Given this list of marker genes Serf2, Hdac8, Supt4a, Mrtfb, Plaat3, Tafa2, Tsg101, Prkce, Pawr, Nck1, Ncoa3, Cxcl16, Nr2f2, Rpl17, Magi1, Lsamp, Chd6, Terf2ip, Plxdc2, Gem, Nectin3, Trmt112, Il18r1, Insig1, Tmem207 (transmembrane protein 207), Atf6, Usp37, Adamtsl3, Snrpn, Cnppd1, Lrrc56, Prrg4, Eif4enif1, Lclat1, Myo16, Parp8, Ankfy1, Zfp790, Dtna, Klhl31, Ube2d3, Tubgcp4, Elovl2, Timp2 (tissue inhibitor of metalloproteinase 2), Brwd3, Kif5c, Tmem252, Cyp26b1 (cytochrome P450, family 26, subfamily b, polypeptide 1), Ppm1k, Tpgs2, Eps8l1, Mkrn1, Dcaf6, Synpo, Ppp1r3a, Klb, Lca5, Uba1, Prl7a2, Gsap, Zfp280c, Htr2c, Gja1, Mcm8, Il1rn, Eya1, Dhx15, Arpin, Smim15, Scaf11, Ehhadh, here is a description of the gene set: Mouse Gene Set: MIR_434_3P Genes predicted to be targets of miRBase v22 microRNA mmu_miR_434_3p in miRDB v6.0 with MirTarget v4 prediction scores > 80 (high confidence targets). species: Mus musculus from publication Chen Y, Wang X (PMID 31504780)